The following is a description of a gene set: Genes predicted to be targets of miRBase v22 microRNA mmu_miR_883b_5p in miRDB v6.0 with MirTarget v4 prediction scores > 80 (high confidence targets). from publication Chen Y, Wang X (PMID 31504780) Mouse Gene Set: MIR_883B_5P studied in species Mus musculus, and this is the list of marker genes: Stag1, Cd84, Svil, Galnt7, Pcsk1n, Ttf1, Ctbp2, Ak7, Ets1, Prdm1, Fbxo10, Pitpnm3, Rere (NCBI Gene Id 68703), Lrrc28, Ugcg, Tnfrsf22, Lrrtm2, Gyg1, Grm3, Pdzrn4, Txlna, Lamc1, Asap1, Pramel30, Erfe, Slc6a4, Klf12, Cybrd1, Sema3b, Chpt1, Shprh, Pmp22 (NCBI Gene Id 18858), Ggta1, Cdh20, Dcaf8, Serpinb10, Strc, Usp9x, Fignl2, Rp1, Spock3 (NCBI Gene Id 72902), Zfp616, Camsap2, E030030I06Rik, Adamts6, Dysf, Pip4k2b, Ppfia4, Marchf8, Stap1, Hmbox1, Pdgfc, 1700037C18Rik, Akap5, Nup98, Nlgn1, Obox5, Ep400, Eif3l, Capza1, Smad2, Slc16a10, Map3k20, Ubtd2, Map3k2 (NCBI Gene Id 320245), Ppp1r18, Ankle2, Srsf1, Tomm20 (translocase of outer mitochondrial membrane 20), Rpgrip1l, Mier1, Mex3c, Smg7, Kctd12b, Ptbp1, Hgf, Ogfrl1, Slain2, Mark3, Mboat2, Nxph1, Mageb16, Lrit1, Nelfe, Cyp3a13, Gclm (glutamate-cysteine ligase, modifier subunit), Synm, Ttll4, Bag5, Csnk1g3 (NCBI Gene Id 70425), Abcc9, Mettl9, Tinagl1, Tnfrsf23, Yipf5, Cltc, Pcmtd1, Fut9, Pramel14, Snap25, Zfp827, Prpf4b, Olfm3, Cdc7, Bcap29, Dpy19l1, Klhl7, Rnf13, Foxn2, Gpam, Zfp945, Gcsam, Rprd1a, Arhgap9, Nfat5, Fmnl2, Obox7, Cdcp3, Med13, Mmp12, Ttc41 (tetratricopeptide repeat domain 41)